Given this list of marker genes Bcl11b, Zfp1004, Hnrnpu, Gad1, 9530068E07Rik, Pdcd1, Zfp1005, Brd9, Ptgr3, Hepacam2, Zbtb24, Aldh1l2, Zcchc9, Fut9, Mafk, Aff4, Faf1, Fbn1, Zfp345, Prkar2b, 2810021J22Rik, Gad2, Hipk3, Scn9a, Slc33a1, Parp12, Itpr1, Cyp4a31, Saa4, Rps6kb1, Arpc1a, Cdk13, Rit1, Tbxas1, Mrpl4, Alg11, Gng12, Pum2, Zfhx4, Cbx5, Cep15 (NCBI Gene Id 73213), Gpr155, Pex10 (NCBI Gene Id 671348), Jade2 (NCBI Gene Id 76901), Pak5, Golm1, Spata6, Cbx6, Csde1, Sh3kbp1, Zbtb7a, Irx2, Zfhx3, Grik2, Map2k1, Unc5d, Trak1, Wtap (NCBI Gene Id 77275), Ints2, Tube1, Cnnm4, Sgcb, Ino80d (INO80 complex subunit D), Eif2s1, Xirp2, Pan3, Zfp503, Gnaz, Usp20, Arap2, here is a description of the gene set: Mouse Gene Set: MIR_3100_3P species: Mus musculus from publication Chen Y, Wang X (PMID 31504780) Genes predicted to be targets of miRBase v22 microRNA mmu_miR_3100_3p in miRDB v6.0 with MirTarget v4 prediction scores > 80 (high confidence targets).